The following is a description of a gene set: Human Gene Set: MIR937_5P species: Homo sapiens from publication Chen Y, Wang X (PMID 31504780) Genes predicted to be targets of miRBase v22 microRNA hsa-miR-937-5p in miRDB v6.0 with MirTarget v4 prediction scores > 80 (high confidence targets)., and this is the list of marker genes: PALM2AKAP2, KCNG3, KIF4A, NCOA2 (nuclear receptor coactivator 2), MASP2, PWWP2A, SEC24A, HCFC1, RAP2A, KCNH7, ADCYAP1R1, RAB1A, RER1, XPO7, NR3C1, SLC24A2, RNF24, FBXO11, IFNA1, CUL2, REV3L, STK17B, DOCK7, ZC3H7A, FAM199X, MGAT4A, GLUD1 (NCBI Gene Id 2746), NFYA, AP3S1, FBXO45, FGD4, LDAH, APAF1, TMEM209, LPP, SLC9A2, MDGA2, TIMM21, MAGEL2, ITGB8, BTG2, WDR33 (WD repeat domain 33), SLC16A14, MCM8, LINC02873, RASSF10, CLIC6, CCNL1, PRIM2, SELENOP, FZD4, NMBR, GRIA1, SRRM4, PMAIP1, GOLGA7